Given this list of marker genes Pnp, Cda, Dck (deoxycytidine kinase), Actn4, Ada, Oard1, Adora1, Pnp2, Polr3b, Oxgr1, Polr2b, Polr1b, here is a description of the gene set: species: Mus musculus Binding to a nucleoside, a compound consisting of a purine or pyrimidine nitrogenous base linked either to ribose or deoxyribose. Mouse Gene Set: GOMF_NUCLEOSIDE_BINDING